Given this list of marker genes PDZD11, KCNJ8, AGRN, LIN7C, LIN7A, MUSK, MYCBP2, LARGE1, COLQ, SIX4, LRP4, LIN7B, SIX1, here is a description of the gene set: Human Gene Set: GOBP_SYNAPTIC_ASSEMBLY_AT_NEUROMUSCULAR_JUNCTION species: Homo sapiens The assembly of a synapse at a neuromuscular junction.